Given this list of marker genes Rbm7, Tro, Rab6a, Zfp106, Esrrg, Man1a, Pgam5, Myt1l, Prnd, Zfp36l1, Pclo, Braf, Rmnd5a, Gpr149, Ncoa5, Trim62, Atrn, Rimklb, Hipk3, Adnp, Rev3l, Aldh6a1, Them4, Hbb-bs, Denr, Sav1, Eif2s2, Wwp1, Cplx1, Csmd3, Filip1l, Myt1, Myh10, Aak1, Ino80c, Art3, Hrct1, Gspt1, Tfec, Paip1, B3galt5, Clcn3, Pafah1b1, Kcnh5, Il7r (interleukin 7 receptor), Arpp21, Spock1, Usp25, Sema7a, Cmc1, Shoc2, Elavl1, Gzmc, Mttp, Eif4g3, Bmpr1a, Stk39, Polr3d, Kcnip4, Cpped1, Enox1, Abr, Slc17a6, Nptx1, Tnrc6b, Phldb2, Prpf4b, Pld5, Piezo2, Stk32b, Glce, Usp9x, Ocln, Camk1d, Prn, here is a description of the gene set: from publication Chen Y, Wang X (PMID 31504780) species: Mus musculus Genes predicted to be targets of miRBase v22 microRNA mmu_miR_682 in miRDB v6.0 with MirTarget v4 prediction scores > 80 (high confidence targets). Mouse Gene Set: MIR_682